The following is a description of a gene set: Abnormal mean corpuscular hemoglobin concentration A deviation from the normal range of the average amount of hemoglobin per red blood cell (27 to 31 picograms/cell). A reduced mean corpuscular hemoglobin (MCH) may indicate a hypochromic anemia, but the MCH may be normal if both the total hemoglobin and the red blood cell count are reduced. species: Homo sapiens Human Gene Set: HP_ABNORMAL_MEAN_CORPUSCULAR_HEMOGLOBIN_CONCENTRATION, and this is the list of marker genes: RNF113A, RHAG, ERCC2, EPB42 (NCBI Gene Id 2038), ERCC3, HELLPAR, PIEZO1, CFH, CFI, SPTB, KCNN4 (NCBI Gene Id 3783), AARS1, TARS1, SPTA1, CARS1, MPLKIP, SLC4A1, HBB, CD46, GTF2H5, GTF2E2, ANK1